The following is a description of a gene set: Human Gene Set: REACTOME_PROSTACYCLIN_SIGNALLING_THROUGH_PROSTACYCLIN_RECEPTOR Prostacyclin signalling through prostacyclin receptor species: Homo sapiens, and this is the list of marker genes: GNG7, GNB1, GNG3, GNGT2, GNB2, GNG5, GNG11, GNG8, GNB4, GNG12, GNG10, GNG13, GNG2, GNAS, PTGIR, GNGT1, GNG4, GNB3, GNB5